Given this list of marker genes GADD45A (growth arrest and DNA damage inducible alpha), CDKN1A, TP53, GADD45G, BAK1, GADD45B, POLK, MDM2, DDB2, BAX, here is a description of the gene set: species: Homo sapiens Pathway Definition from KEGG: EBNA3C -> MDM2 -| TP53 => (CDKN1A,GADD45,BAX,BAK1,DDB2,POLK) EBV EBNA3C to p53-mediated transcription. Pathway ID: N00263. Pathway type: Pathogen. Pathway class: nt06165 Epstein-Barr virus (EBV). Human Gene Set: KEGG_MEDICUS_PATHOGEN_EBV_EBNA3C_TO_P53_MEDIATED_TRANSCRIPTION